The following is a description of a gene set: Human Gene Set: DASU_IL6_SIGNALING_DN from publication Dasu MR, Hawkins HK, Barrow RE, Xue H, Herndon DN (PMID 15095275) studied in species Homo sapiens The structural rearrangement of collagen fibres in hypertrophic scar causes abnormal contracture, low tensile strength, and raised scars, which cause functional impairment and disfigurement. It is hypothesized that changes in the genes of cytokines, extracellular matrix proteins, and proteins regulating programmed cell death are related to hypertrophic scar formation. To test this hypothesis, fibroblasts were cultured from hypertrophic scars and their response to interleukin-6 (IL-6) stimulation was studied by defining their gene expression profiles. Affymetrix gene chip analysis was used to identify up- or down-regulation in the genes present in the affymetrix array. RT-PCR and ELISA assays were used to validate microarray expression profiles further. Comparison of gene profiles showed an increase of genes in hypertrophic scar fibroblasts compared with normal skin fibroblasts, while the expression of genes decreased. Thirty-three genes were affected by IL-6 treatment in the hypertrophic scar fibroblasts, while genes were affected in normal skin fibroblasts. Messenger RNA to beta-actin ratios for matrix metalloproteinase-1 (MMP-1) and MMP-3 were increased with IL-6 in normal skin fibroblasts from 2.43 +/- 0.06 to 5.50 +/- 0.45 and from 0.75 +/- 0.09 to 1.98 +/- 0.01, respectively. No change in these matrix metalloproteinases could be shown with IL-6 stimulation in hypertrophic scar fibroblasts. Secreted protein levels of pro-MMP-1 and MMP-3 were elevated in the supernatants from normal skin fibroblasts from 2.00 +/- 0.09 and 1.72 +/- 0.10 ng/ml to 4.60 +/- 0.12 and 3.41 +/- 0.20 ng/ml, respectively, after treatment with IL-6 (p < 0.05). No changes were observed in hypertrophic scar fibroblasts treated with IL-6. Values are means +/- SEM. The absence of any up-regulation of MMP-1 and MMP-3 in hypertrophic scar fibroblasts, in response to IL-6, suggests that suppression of matrix metalloproteinases may play a role in the excessive accumulation of collagen formed in hypertrophic scars. While the pathogenesis of abnormal hypertrophic scars remains poorly understood, the use of gene expression arrays may prove helpful in identifying the mechanisms responsible for this type of abnormal scar formation and in formulating an effective therapeutic protocol. Genes down-regulated in normal fibroblasts in response to IL6., and this is the list of marker genes: SERPINE1, TMBIM6, SEPTIN11, TPM1, SULF1, ASNS, PPP1R3C